The following is a description of a gene set: Genes up-regulated by telomere shortening due to the knockout of TERC in the presence of chronic liver damage. studied in species Mus musculus from publication Wiemann SU, Satyanarayana A, Buer J, Kamino K, Manns MP, Rudolph KL (PMID 15608677) Mouse Gene Set: WIEMANN_TELOMERE_SHORTENING_AND_CHRONIC_LIVER_DAMAGE_UP Telomere shortening limits the regenerative capacity of cells during aging and chronic disease but at the same time inhibits tumor progression, and it has yet to be determined which of these mechanisms is dominantly affecting organismal survival. Here we show that telomere shortening in telomerase knockout (mTERC-/-) mice in combination with chronic liver damage significantly reduced organismal survival even though telomere shortening strongly inhibited liver tumor formation. Decreased survival induced by telomere shortening correlated with an imbalance between liver cell proliferation and liver cell apoptosis. Specific changes in gene expression were associated with telomere shortening and chronic liver damage and these gene expression changes were partially reversed by adenovirus mediated telomerase gene delivery. This study gives experimental evidence that the negative impact of telomere shortening on organ homeostasis and organismal survival can surpass the beneficial effects of telomere shortening on suppression of tumor growth in the setting of chronic organ damage., and this is the list of marker genes: Cry1, Cyp2b9, Erdr1, Alad, Cyp4a10, H1f2, Orm3, Aurka, Bmal1, Gpi1, Ces1c, Tubb2a